The following is a description of a gene set: studied in species Mus musculus Any process that stops, prevents or reduces the frequency, rate or extent of stem cell differentiation. Mouse Gene Set: GOBP_NEGATIVE_REGULATION_OF_STEM_CELL_DIFFERENTIATION, and this is the list of marker genes: Ncoa3, Nelfb, Hspa9, Nfe2l2 (NCBI Gene Id 98874), Hnrnpu, Notch1, Yap1, Ccnk, Zfp36l2 (zinc finger protein 36, C3H type-like 2), Zfp36, Esrrb, Hes5, Rest, Tcf15, Jag1, Stat3, Cdk12, Prickle1, Nanog, N4bp2l2, Ythdf2, Gsk3b, Lbh, Cdk13, Ezh2, Tmsb4x, Trim6, Mir125a, Bbs12, Mir154, Tbx3, Hes1